Given this list of marker genes Aspg, Atf4, Asnsd1, Asrgl1, Asns, Nit2, here is a description of the gene set: The chemical reactions and pathways involving asparagine, 2-amino-3-carbamoylpropanoic acid. species: Mus musculus Mouse Gene Set: GOBP_ASPARAGINE_METABOLIC_PROCESS